The following is a description of a gene set: from publication Yevshin I, Sharipov R, Kolmykov S, Kondrakhin Y, Kolpakov F (PMID 30445619) Human Gene Set: ZSCAN21_TARGET_GENES Genes containing one or more binding sites for (ZSCAN21) in their promoter regions (TSS -1000,+100 bp) as identified by GTRD version 20.06 ChIP-seq harmonization. species: Homo sapiens, and this is the list of marker genes: PLEKHA8P1, MIR1302-3, MAP1A, KDM8, CCNI, PKNOX1, PURB, ELP3, TBPL1, SUMF1, SUGT1P3, TPTE2P5, TDP1, DEPTOR, REX1BD, KIF12, CFAP74, FRG1HP, CEP57L1, BRWD1, ZFP30, THADA, ANO6, KDM1A (lysine demethylase 1A), SLC11A2, PDE7B (phosphodiesterase 7B), FRA10AC1, MYL6, ATP6V1G2-DDX39B, JMJD1C, CPSF2, KRBA2, ARID5B, IDH3B, TMEM208, ZNF827, LMBR1, PRDX1, DNAH6, LINC01547, SH3D21, KDM4A, STAT6, BIN1, RNU1-6P, NUP214, H2BC26, TIGD6, ASH1L, KRBA1, MTCL3, H2BC12, TOP3B, SPEG, OAT, RXFP4, MATCAP1 (microtubule associated tyrosine carboxypeptidase 1), RBM15, CLN8, SEMA6A, BACH1, RSBN1, CNIH3, ECH1, CLSPN, TATDN3, LBX1-AS1, SOD1-DT (NCBI Gene Id 102724449), CDKL3, MRPL54, TSHZ2, VWA8-AS1, ARSK, POC1B-GALNT4, SRSF5 (serine and arginine rich splicing factor 5), IL17RD, RANBP9, COQ10A, PCDHB2, ADRA1A, IL17RA, CCNB1IP1, PIKFYVE, AHSA1, POC1B, DCAF8-DT, EPC1-AS1, FAAH2, TMEM167B, USPL1, SYNPO2, SH3PXD2B, PPP4R1L, SOD1, ENAH, CFAP206, LSM11, SLC12A2, LGI4, TMEM191A, ANKRD13C, ZNF585B, SNHG30, SLC25A37, CD8A, STX1B, RPLP1, INO80E, MCTP1, ZNF263, MDM2, WDR83, FASTKD5, MAST4, SPATA2, KLHDC3, NCOA6, CCDC90B-AS1, RNU2-17P, ADD3, SMAD7, ACBD7, GADD45G, NCOR2, IFNGR1 (interferon gamma receptor 1), ELOA-AS1, TMEM161A, KRT80, EPC1, DNAAF9, CD58, SLC12A2-DT, SESN1, LAMC1, TOB2, AGK-DT, PDS5A, MCPH1-AS1, MICALL1, CUL2, PLEKHG2, SKIC3, GTPBP3, DTWD1, ASCC1, ZNF566, ARNT, ENSG00000247416, SRFBP1, MIR3143, NFKBIL1, MIR7974, DRG2, CMTR1, ZNF391, RMND5B, KAT6A, VPS33A, TMEM167B-DT, TGFBR2, CBFA2T2, SULT1A1, RBM28, TMBIM4, COA1, ZNF608, RALGDS, EPB41L4A-AS1, TLCD5, SNORD12C, NRP1, FNTA, KCNK1, ADD3-AS1, TRDMT1, IRAIN, MAP2K5, RNF220 (NCBI Gene Id 55182), NBPF1, CDKL1, MRPL22, RBM39, MEA1, GPHN, ZNF624, TTI2, SBK1, SLC9A1, KLRK1, FAM227B, GNAL, NCAM1, RITA1, TMCC2, GPR89B, HTR3A, EXTL3, SPAG9, PFKFB4, QKI, TXNDC15, HLA-DQA1, KLHL20, BRF2, C6orf226, CTNNA1-AS1, SNORA13, PCDH1, SYCP2, DARS2, COL4A5, ZNF326, RBM8A, HEXIM1, LINC01003, BBX, HSDL2-AS1, FRAS1, DCP1A, MYL6B-AS1, COL4A6, PPFIBP1, PSTK, RCAN1, LINC00240, TEFM, ELP5, JPX, SF3A3, GALNT2, VTA1, APBA3, RNVU1-31, CASC3, PRKD3-DT, ZMPSTE24, NSL1, CAPZA2, PDXK (NCBI Gene Id 8566), LSM1, RNF43, ARHGEF18-AS1, TEDC2-AS1, BBS4, C10orf88, SGSM1, MAZ, ANO8, ANP32E (NCBI Gene Id 81611), DNAJB6P3, RNF24, TBC1D13, MGLL, ZNF136, MTMR9, CCNC, CCDC192, S100A2, UBOX5, NBPF19, COX15, EML2, ANXA2, APC2 (APC regulator of WNT signaling pathway 2), VRTN, FIS1, PIK3R1, SHF, TMEM248, AP3S2, VARS2, TIMM17A, SH2D5, CENPK, WDR83OS, ATP6V1G2, WDR62, SUV39H2, SLC46A3, TLK2, MYO5C, VWA8, MAML3, ZNF850, AJUBA-DT, PISD, RHOC, FUS, HRK, ZNF30, TMEM191B, CFAP410, PDCD6IP, NDUFB1, TMEM50B, ZNF30-AS1, NBPF3, COX16, RGS5, RPL27, CNN3-DT, NUP43, FRMD4A, IDH1, HIRIP3, CSNK1D (casein kinase 1 delta), LINC02985, NOG, SMAP2, COQ8B, MBTPS2 (NCBI Gene Id 51360), STX8, ZNFX1, PHF3, DNAJB12, INTS12, WWTR1, CENPH, ATP2B4, ADAM22, NFIA-AS1, CDADC1, SMG7-AS1, HOXB-AS3, THAP8, WTAP, GPR85, DYM (NCBI Gene Id 54808), NPRL3, SIAH1, TASOR2, SLX9, DYNC2I2, TENT5B, EHD1 (NCBI Gene Id 10938), CLASP2, DYSF, ZKSCAN3, ALDH1A2 (NCBI Gene Id 8854), ZNF302, TP53BP2, SMG7, MAP4K3-DT, LINC00921 (NCBI Gene Id 283876), AJUBA, RAVER2, INTS2, DNAJC28, TSC22D4, NDUFS7, MRPL1, CFDP1, PHF8, ZNF501, SFT2D3, ADGRG1, NACA, CDC42EP4, HMGB1, RWDD2B, MRPL39, ZNF790, CEBPG, NBPF25P, WEE2-AS1 (WEE2 antisense RNA 1), RHOBTB3, SLU7, ZMPSTE24-DT, MAP3K21, RFTN1, AKIRIN2, C6orf58, AGK, ERGIC1, KRT75, GPR89A, ZNF408, RNU6-859P, EXOSC3, GEMIN8P4, ABCD4, PBX1, SORBS2, PSMD10, PFKM, CTNNA1, GTF2H4, NOP16, RNU7-27P, H3C9P (H3 clustered histone 9, pseudogene), VTRNA1-3, MAPK14 (NCBI Gene Id 1432), RND2, NDUFAF1, SCAND3, LAMTOR5, ANGEL2, CLCN3, NTMT1, SPINT2, TMEM255A, DNAJB4, SLC22A4 (NCBI Gene Id 6583), IKBKE, RNF150, USP4, CENPL, CEP112 (centrosomal protein 112), DMAP1, FAM199X, HOXB3, KIAA1191, CDC42EP1, ZNF114, SLF1, ZC3H7A, USP30, PRR14, NCL, ZKSCAN2, ZFAS1, ETFA, GTF3C5, BAG4, RBFOX2, SRSF7, TOR1AIP1, MSANTD3, SCARNA2 (small Cajal body-specific RNA 2), NUF2, DDX54, SSBP1, NUFIP2, DNAAF4-CCPG1, TARS2, SLC44A1, RPL37, ENSG00000246465, INTS14, GBA1, GEMIN6, FBXL9P, TP53BP1, SNX10-AS1, PLEKHM3, ENSG00000232995, C1orf220, LINC00431, EFCAB11, PLEKHM1, AHNAK (AHNAK nucleoprotein), NSRP1, TNRC6B, PRKD3, ADAP2, LINC02832, AATBC, TRMT1, PARP1, RINT1, ZNF865, LAMTOR5-AS1, FAM111B, ADAR, WDR26, KIAA1958, MTF2, TNS2-AS1, PLCXD2, TRAF4, CSNK1E, LIX1L-AS1, PTTG1, IGSF3, DNAAF4, CHN1, HDGFL3, SULF1, EIF3J, H2BC18, ZNF540, EIF3J-DT, LZTS3, SLC24A1, KPNA1, GSTCD, ARID2, DMAC2L, HP1BP3, KLHDC9, FAM133B, CFAP52, FAM184A, ZBTB8B, ENSG00000267260, IDH3B-DT (IDH3B divergent transcript), INPP4B, COQ8A, CDK5RAP1, PREX2, CTDNEP1, AHCYL1, PRC1, PPWD1, PCAT19, LAMP1, GLI3 (GLI family zinc finger 3), RANBP3L, TTLL7, CPEB4, LRP6 (NCBI Gene Id 4040)